The following is a description of a gene set: Any process that stops, prevents or reduces the frequency, rate or extent of p38MAPK cascade. studied in species Mus musculus Mouse Gene Set: GOBP_NEGATIVE_REGULATION_OF_P38MAPK_CASCADE, and this is the list of marker genes: Dlg1, Cyld, Ptpn22, Trem2, Dusp1, Dsg3, Dusp10, Ezr